The following is a description of a gene set: In this study, an extensive analysis was conducted to define meta-programs (MPs) capturing intra-tumor heterogeneity across a spectrum of tumor types. The approach utilized non-negative matrix factorization (NMF) to analyze each cell type separately within individual tumor samples. This involved the analysis of malignant cells, macrophages, fibroblasts, endothelial cells, epithelial cells, T-cells, and B-cells. NMF was executed with varying parameter values (K=4, 5, 6, 7, 8, 9), thereby generating 39 programs for each cell type per sample. Each NMF program was summarized by the top genes based on NMF coefficients.\nRobust MPs were then delineated for each cell type using a set of stringent criteria, including recurrence within the same tumor, similarity to programs in other tumors, and non-redundancy within a tumor. Subsequently, these robust NMF programs were clustered (per cell type) based on Jaccard similarity, leading to the identification of MPs associated with each cell type.\nTo enhance the quality of the MPs, a refinement steps were undertaken, involving the removal of MPs suspected of reflecting low-quality data (with an overrepresentation of ribosomal proteins or mitochondrial-encoded genes), single-study inclusion, or similarity to miss-annotated cell types. studied in species Homo sapiens Human Gene Set: GAVISH_3CA_METAPROGRAM_MACROPHAGES_MAC_1 from publication Gavish A, Tyler M, Greenwald AC, Hoefflin R, Simkin D, Tschernichovsky R, Galili Darnell N, Somech E, Barbolin C, Antman T, Kovarsky D, Barrett T, Gonzalez Castro LN, Halder D, Chanoch-Myers R, Laffy J, Mints M, Wider A, Tal R, Spitzer A, Hara T, Raitses-Gurevich M, Stossel C, Golan T, Tirosh A, Suvà ML, Puram SV, Tirosh I (PMID 37258682) Genes upregulated in subsets of cells of a given type within various tumors, and this is the list of marker genes: MS4A7, MT2A, HES1, RAC2, LILRA1, CFD, MYO1G, S100A9, VAMP5, CYTIP, FCGR3A, LY6E, CDKN1C, LTA4H, COTL1, SPN, LILRB2, RHOC, IFITM2, PLAC8, HCK, NAAA, CD55, LYST, APOBEC3A, SERPINA1, CD48 (NCBI Gene Id 962), CFP, WARS1, ABI3, BCL2A1, TIMP1, LST1, CRIP1, MAFB, PELATON, STXBP2, CD52, MTSS1, FCN1 (ficolin 1), CLEC12A, S100A4, S100A8, LRRC25, LILRA5, IFITM3, FGR, POU2F2, CORO1A, TCF7L2